The following is a description of a gene set: Human Gene Set: MCLACHLAN_DENTAL_CARIES_DN Genes down-regulated in pulpal tissue extracted from carious teeth. High-throughput characterisation of the molecular response of pulpal tissue under carious lesions may contribute to improved future diagnosis and treatment. To identify genes associated with this process, oligonucleotide microarrays containing approximately 15,000 human sequences were screened using pooled total RNA isolated from pulpal tissue from both healthy and carious teeth. Data analysis identified genes with 2-fold or greater difference in expression level, with 85 more abundant in health and 360 more abundant in disease. Subsequent gene ontological grouping identified a variety of processes and functions potentially activated or down-modulated during caries. Validation of microarray results was obtained by a combination of real-time and semi-quantitative PCR for selected genes, confirming down-regulation of Dentin Matrix Protein-1 (DMP-1), SLIT 2, Period-2 (PER 2), Period-3 (PER 3), osteoadherin, Glypican-3, Midkine, activin receptor interacting protein-1 (AIP 1), osteoadherin and growth hormone receptor (GHR), and up-regulation of Adrenomedullin (ADM), Interleukin-11 (IL-11), Bone sialoprotein (BSP), matrix Gla protein (MGP), endothelial cell growth factor-1 (ECGF 1), inhibin beta A and orosomucoid-1 (ORM 1), in diseased pulp. Real-time PCR analyses of ADM and DMP-1 in a panel of healthy and carious pulpal tissue and also in immune system cells highlighted the heterogeneity of caries and indicated increased expression of ADM in neutrophils activated by bacterial products. In contrast, DMP-1 was predominantly expressed by cells native to healthy pulpal tissue. This study has greatly extended our molecular knowledge of dental tissue disease and identified involvement of genes previously unassociated with this process. from publication McLachlan JL, Smith AJ, Bujalska IJ, Cooper PR (PMID 15869869) studied in species Homo sapiens, and this is the list of marker genes: COL8A2, ANK3 (NCBI Gene Id 288), LGR4, H3-3B, CDH12, CPE, EIF1AX, SLIT2, MPPED2, LINC00667, POLI, SPON1, GAP43, PHLPP1, PHIP, NRXN1, ITM2A, SPOCK1, GPC3 (glypican 3), PDZD2, PER2, PCDH9, KIF5C (NCBI Gene Id 7860), NEBL, CD24, DIO3, CRYZ, GPR37, OLFML1, DMP1 (NCBI Gene Id 1758), AHNAK, MAGI2, COL5A3, LTBP1, XIST, PGAP1, GPM6A, TMEM255A, PLK2, TIAM1, LGR5, SORBS2 (sorbin and SH3 domain containing 2), ACTR3B, AOC2, PDZD8, PEG10, EGR1, OMD, CRABP1, DPP6, PTPRK, CYFIP2, SYT1, TRPC1, MDK, CALB1, ATP9A, ADIRF, SPOCK3, DSPP, CCN1, TRIM2, NUDT4, CA2, ADGRG2, GLCE, GHR, PER3, ATP1A2, SESN1, OSR2, NAP1L3, ABLIM1, ISYNA1, TUBB2B, FGFR1, KIT, NOTCH2NLA, PLCL1, ZNF423, ST8SIA1, ITGB1BP1